Given this list of marker genes Cdkl3, Srf, Zeb2 (NCBI Gene Id 319891), Ntrk3, Dscam, Ndel1 (NCBI Gene Id 83431), Wnt3, D130043K22Rik, Tsc2, Wnt3a, Stk11, Syngap1, Ep300, Slitrk1, Map6, Adcy10, Epha7, Dcx, Bmpr2, Amigo1, Braf, Ust, Cxcl12, Anapc2, Ephb2, Map1b, Crabp2, Tnr, Grin1, Robo2, Ist1, Apoe, Ntn1, Cdkl5, Pak3, Efna1, Hdac6, Plxna3, Trpv2, Nrp1, Cdh1, Ntrk2, Eif4g2, Golga4, Snap91, Tnfrsf12a, Dixdc1, Pou4f2, Fgf13, Trim46, Bcl11a, Nrdc, Ccr5, Kel, Efnb3, Sema3f, Wnt5a, Zfyve27, Tiam1, Plxnb2 (plexin B2), Skil, Fn1, Sema3g, Sema7a, Trak1, Dab1, Dbn1, Fstl4, Vim, Slit2, Sema3a, Slit1, Golga2, Actr3, Myo5b, Cacna1a, Map2k2, Arhgap32, Islr2, Spart, Cdk5, Mapt, Ulk1, Ilk, Chn1, Rnf6, Ifrd1, Omg, Sema4f, Nefl, Picalm, Rufy3, Ret, Sema6d, Tiam2, Lrp4, Adnp, Kif13b (NCBI Gene Id 77105), Sema4d, Thy1, Ptprs, Metrn, Ptk2, Psen1 (presenilin 1), Gdi1, Mag, Trak2, Macf1, Robo1, Draxin, Pafah1b1, Epha4, Sema6c (NCBI Gene Id 20360), Gsk3b, Cyfip1, Gla, Map2, Brsk1 (NCBI Gene Id 381979), Disc1, Trpc5, Mbp, Twf2, Dip2b, Megf8, Vegfa, Pak1 (p21 (RAC1) activated kinase 1), Wnt7a, Plxnc1, Efna5, Ttc3, Xk, Arhgap35, Pak2, Sipa1l1, Fxn, Limk1, Brsk2, Chodl, Cdh4, Shox2 (NCBI Gene Id 352985), Cdh2, Rgma, Sema5a (sema domain, seven thrombospondin repeats (type 1 and type 1-like), transmembrane domain (TM) and short cytoplasmic domain, (semaphorin) 5A), Mark2, Rnd2, Ephb3, Plxnb1, L1cam, Ngf, Dbnl, Ulk2, Nefm, Rtn4, Map3k13, Nin, Pou3f2, Ache, Pten, Plxnb3, Bdnf, Smurf1, Shtn1, Ryk, Stk25, Rtn4r, Plxnd1, Lrrc4c, Eif2b2, Rpl4, Arhgap4, Cntn2, Mt3, Lrp1, Lpar3, Map2k1, here is a description of the gene set: Any process that modulates the frequency, rate or extent of axonogenesis, the generation of an axon, the long process of a neuron. species: Mus musculus Mouse Gene Set: GOBP_REGULATION_OF_AXONOGENESIS